The following is a description of a gene set: studied in species Homo sapiens Supernumerary cusp Human Gene Set: HP_SUPERNUMERARY_CUSP Additional cusps of a dental crown., and this is the list of marker genes: EP300, NEK1, NHS, CREBBP, CHSY1